The following is a description of a gene set: from publication Foster SL, Hargreaves DC, Medzhitov R (PMID 17538624) Genes down-regulated in macrophages: naïve untreated versus tolerant stimulated by LPS. studied in species Homo sapiens Human Gene Set: GSE7348_UNSTIM_VS_TOLERIZED_AND_LPS_STIM_MACROPHAGE_DN The inflammatory response initiated by microbial products signaling through Toll-like receptors (TLRs) of the innate immune system is essential for host defense against infection. Because inflammation can be harmful to host tissues, the innate response is highly regulated. Negative regulation of TLR4, the receptor for bacterial lipopolysaccharide (LPS), results in LPS tolerance, defined as hyporesponsiveness to repeated stimulation with LPS. LPS tolerance is thought to protect the host from excessive inflammation by turning off TLR4 signal, which then shuts down TLR-induced genes. However, TLR signaling induces hundreds of genes with very different functions. We reasoned that genes with different functions should have different requirements for regulation. Specifically, genes encoding proinflammatory mediators should be transiently inactivated to limit tissue damage, while genes encoding antimicrobial effectors, which directly target pathogens, should remain inducible in tolerant cells to protect the host from infection. Using an in vitro system of LPS tolerance in macrophages, here we show that TLR-induced genes may indeed be divided into two distinct categories based on their functions and regulatory requirements. Further, we show these distinct groups are regulated by gene-specific, and not signal-specific mechanisms., and this is the list of marker genes: PSMB10, SCML4, COX18, TMEM67, HERC5, DUSP16 (dual specificity phosphatase 16), IL1RAP (interleukin 1 receptor accessory protein), MPPE1, STX11, TNFAIP3, LIPE, IRF1, TNFRSF1A, MAX, RASA4, ETNK1 (ethanolamine kinase 1), TPST1, CPEB3, PLEKHA2, PPP2R2A, OTUD5, CDC42EP2, FAM53C, NFXL1, DCK, PTTG1, TUT4, ITPR1, USP12, LLGL1, PRKCQ, HIVEP3, TOX4, NAMPT, SHISA6, TM2D1, BRI3, TUT7, ADAMDEC1, EP400, NUDT13, DBNL, TPBG, ATOH1, CXCL1, HAP1, CEMIP2, RNF14, BBX, IL12RB1, RAB38, CRABP2, SH3BP4, GPR26, MARCKS, IL15RA (interleukin 15 receptor subunit alpha), ZC3HAV1, ELF1, CTRL, TYK2, PHF11, ZEB1, ABTB2, CASP1, NKX6-3, DENND6B, TBX15, PSME4, ENG, IL15, INPP5B, KREMEN1, FBXO4, SMG7, TNIP1, ATP10A, DDX60, GGCT (NCBI Gene Id 79017), CCDC50, MAP3K8, USP25, TAGLN3, RELB, DEDD, HSH2D, BCKDHB, FAS (Fas cell surface death receptor), PARP12, ZCCHC2 (zinc finger CCHC-type containing 2), TEAD3, UBTD2, HAND2, ZUP1, MMP13, IFI35, NFKB1, SHOC1, SOD2, CCNJ, PSMB8, SP110, WDR37, PPP1R15A, MLKL, TUBA8, EIF2AK2, ARID5B, RGL1, RASGEF1B, MARCKSL1, EN1, LCP2, SVBP, FOXP1, TLK2, CASP4, ADHFE1, SNW1, ZC3H15, MOB1A, PGS1, CYCS, RGS9, FGFR2, SLC2A6, MYBPC3, ARL4A, LRCH1, GOLGA3, TM9SF4, TMEM171, DYRK2, RMDN3, PTGES, PIWIL4, CALCRL, PSMB9, ACOT9, PLSCR1, ISG15, DHH (NCBI Gene Id 791256), MARCHF5, PCGF5, RIPK2, SLC28A2, TENT4A, SNX10, AZI2, B3GNT2, CCDC25, MTDH (metadherin), CRLF3, NECTIN4, SAMD9L, CFLAR, CRYBG1, SOWAHC, MXD1, PTPRJ, MST1